Given this list of marker genes SH3D19, UTRN, ADRA1A (NCBI Gene Id 148), ACADS, BPNT1, PDE4DIP, FHOD3, MMP17, AGTRAP, PTGDS, MRPL49, PAM16, ACSF3, HOXB9, PCSK6, CA14, CCDC93, FGFR4, AGER, MYH3, SLC16A8, PVT1, GRIA4, MSH6, HSD17B3, GBA1, COQ5, ZNF281, PDGFRA, CMTR2, REPIN1, KLF9, PIGR, RPL39, FKBP10, PLEKHA7, SMARCD1, FKBP4, PSEN2, SYT3, PPP5C, LSM14B (LSM family member 14B), ASPM, CHRNA7, UXS1, RGS6, DLG3, MERTK, COPS7B, EFNA4, CRLF3, CALR, KCNS2, MPZL2, HRH2, TFEB, SPINK1, PIH1D1, SNTB1, TRH, C1QBP, OXSM, KRT33B, USF2, HSPA4L, AOX1, RAD23B, TMEM40, MTR, DYNLL2, CKAP5, PDE7A, KCNE1, RFC1, NPPC, SLC25A15, SNTB2, PBX2, MDM4, POLE4, DEAF1, F2R, THRA, CES1, ERI2, CNR2, NPTX2, NUCB1, DNASE1L3, AATK, FGF1 (NCBI Gene Id 29961), CYP17A1 (cytochrome P450 family 17 subfamily A member 1), HPF1 (NCBI Gene Id 54969), G6PC1, RBP2, IL18R1, AQP4, SYPL2, ZNF292, COLQ, ETV4, CDKN2D, FANCC, SET (NCBI Gene Id 6418), ST6GALNAC4, GLRX, CCDC28B, CRCT1, KCNN1 (potassium calcium-activated channel subfamily N member 1), PSMD5, CNOT6L (NCBI Gene Id 91275), MTF1, TTC7B, MOGAT2, NTN1, PLA2G2A, GGT5, SEMA3A, HPCA, EPO, PDLIM1, ROS1, RFNG, MMP15, ACO1, RPS6KA3, ANK3, CYP7B1, TSKS, LGALS7, ZFPM2 (NCBI Gene Id 56958), DUSP12, SSTR3, LPCAT1, PINK1, SYT11, UBQLN1, HAPLN1, PLXND1, SLC29A1, FAM83H, UROS, TBX6, RCBTB1, ATP7B, TSEN34, GINM1, GGCX, ST3GAL5, DLX6, DDX46, NCAPH, ATXN1, PRSS8, MYO1B, RALBP1, RBMS2, FZD1, TSPY1, SH3BP5, ZDHHC14, TBCEL, PLA2G12A, AMOTL2, RASGRP1, PBX3, CD22, BSN, UQCC5, NOS2, KLHL7, PLXNB2, DHRS4, ASS1, TYK2 (NCBI Gene Id 7297), CNN3, EPB41L2, ESRRA, CLCC1, NICN1, SLC1A2, IL11RA, RASGRF1, SHMT2, UNG, FAM13B, TNFSF10, BTF3L4, PTGER2, LCT, SEPTIN7 (septin 7), RNF141 (ring finger protein 141), CAPN2, GSC, R3HCC1, PDE6G, POLA1, GPR83, WNK1, NDUFB3, here is a description of the gene set: Expression profiling of Rag2-deficient Ets1++ and Rag2-deficient Ets1-- mature NK cells and WT bone marrow progenitors, WT T cells, and WT Pro B cells from publication Ramirez K, Chandler KJ, Spaulding C, Zandi S, Sigvardsson M, Graves BJ, Kee BL (PMID 22608498) Human Gene Set: GSE37301_LYMPHOID_PRIMED_MPP_VS_COMMON_LYMPHOID_PROGENITOR_UP Genes up-regulated in lymphoid primed multipotent progenitors versus common lymphoid progenitors. studied in species Homo sapiens